The following is a description of a gene set: Genes predicted to be targets of miRBase v22 microRNA hsa-miR-3619-3p in miRDB v6.0 with MirTarget v4 prediction scores > 80 (high confidence targets). from publication Chen Y, Wang X (PMID 31504780) Human Gene Set: MIR3619_3P studied in species Homo sapiens, and this is the list of marker genes: PCDHA3, PCDHA1, OCIAD1, MED13, COL4A1, PCDHAC2, TAOK1, IKZF5, TET3, SMDT1, PADI2, ZC3H7B, PCDHA10, TTBK2, PCDHA7, RFC5, CASP10, EPB41L3, PCDHA5, PCDHA2, LYSMD3, PCDHAC1, MSI2, IPO11, PCDHA13, MCHR2, ZFP28, COL25A1, SMCO4, PCDHA4, TMPO, TNFSF10, PCDHA12, PCDHA11, CTNNB1, KRT19, PSMA8, VPS36, PCDHA9, PCDHA6, N4BP2, SOCS6, GMFB, PIK3C2A, SMC2, ARHGAP29 (NCBI Gene Id 9411), CYP4F3, KMT2C, MITF